Given this list of marker genes ELMO2, EFL1, SLC40A1, INTS14, PARK7, RAP1GAP, CCDC127, TMEM242, PTPN18, ARFRP1, CAPN7, EML5, FAM98A, MBD3, FKBP11, MSL3, PSMC4, HSPA4, BDH1, ERCC8, THRAP3, GPX4, GLMP (NCBI Gene Id 112770), TOP1MT, CRK, F8A1, TRMT10A, SAMD4A, DIP2B, SCML2, RBX1, CCT5, NAA40, MPP3, MCM3, HIP1, QDPR, LSM3, GALC, TIMM9, NEDD8, RAP1A, DAD1, DNAJB9, NFATC1, SPRYD4, DCAF12, OPA3, TACR3, CSTB, DHX30, DNLZ, PTDSS2 (NCBI Gene Id 81490), DPH2, CNOT9, CCER1 (coiled-coil glutamate rich protein 1), N4BP3, MTAP, MAPK3, NEDD1, IMPA2, CXorf38, HAUS8, SLC25A13, SVIL (supervillin), ANLN, OXR1, SIRT3, LEPROT, COPS5, FDFT1, C1orf174, BAZ2A, PCNA, CISD1, SRSF9, SSU72, FMO1, ACADVL, UBE2N, MRM1, PTK6, NATD1, PACC1, MRPL47, RETREG1, RNF7, CDIP1, DUSP19, MLH1, STAU2, IQGAP3, CCNI, POC5, SLC2A1, ARMC6, OSBPL2, GLO1, FAM76A, BPIFA2, MTFMT (NCBI Gene Id 123263), RNF38, LCLAT1, PPP1CC, RGS19, PDXK, RASSF5, RFX1, ESCO1 (NCBI Gene Id 114799), ATP5F1B, KIF1C, NCAPH, ANKRD28, CPT2, TNFRSF21, FAM118B, TUBGCP2, MANBA, PER3, NUCKS1, AAAS, SMC3, PTPN1, TUBA1A, CROT, RFX2, ACOT13, CAPRIN1, MRPL44, QTRT1, PIGS, PDCL, ADIPOR2, RPA2, NDUFS7, CAPN15, NGB, HAUS4, MKNK2, FDPS, MCM7, ELOF1, QRSL1, CCDC137, PRPF3, HPF1, GTF3C1, KLHL9, RRM2, CD48, CYRIB (CYFIP related Rac1 interactor B), IMPACT, STK40, ECH1, GIT1, PTP4A2, BRCC3, RDH14, OGFOD2 (2-oxoglutarate and iron dependent oxygenase domain containing 2), MED7, PEX2, CLCN6, TANGO2, DNAJB2, TIMM8A (translocase of inner mitochondrial membrane 8A), FUOM, DDX39A, RAMP1, NEAT1, TFRC, SPEF1, KIFC1, ADRA1A, FBXO33, C15orf40, MSH6, TULP4, MED29, BICD2, SLC23A3, PRKAG1, PIGC, CCT8, C19orf53, KLHDC4, HNRNPLL, RABAC1, PLS3, TMLHE, METTL3, SLC25A46, TCF25, RTCB, TSR1, GPR146, LRP6, TMEM208, ABTB1, AP2S1, TADA2A, here is a description of the gene set: studied in species Homo sapiens from publication Amit I, Garber M, Chevrier N, Leite AP, Donner Y, Eisenhaure T, Guttman M, Grenier JK, Li W, Zuk O, Schubert LA, Birditt B, Shay T, Goren A, Zhang X, Smith Z, Deering R, McDonald RC, Cabili M, Bernstein BE, Rinn JL, Meissner A, Root DE, Hacohen N, Regev A (PMID 19729616) Human Gene Set: GSE17721_CTRL_VS_POLYIC_4H_BMDC_UP Genes up-regulated in comparison of control dendritic cells (DC) at 4 h versus those stimulated with poly(I:C) (TLR3 agonist) at 4 h. mouse primary BMDCs were stimulated with tlr ligands and gene expression changes were profiled on Affymetrix arrays